The following is a description of a gene set: species: Homo sapiens Human Gene Set: GOBP_PHOSPHATIDYLINOSITOL_3_KINASE_PROTEIN_KINASE_B_SIGNAL_TRANSDUCTION An intracellular signaling cassette that starts with phosphatidylinositol 3-kinase (PI3K) activation, production of phosphatidylinositol 3-phosphate (PI3P), activation of PDK1, which recruits and ending with the activation of protein kinase B (PKB, also known as Akt). PI3K is activated by cell surface receptors. Note that PTEN is an inhibitor of the pathway., and this is the list of marker genes: FYN (NCBI Gene Id 2534), IGFBP5, WDR91, MYO16 (NCBI Gene Id 23026), PIP5KL1, THEM4 (NCBI Gene Id 117145), PROS1, INPP5F, MYORG, DCN, NTRK3, PRKD1, MYOC, NTF3, CHI3L1, RAC1, NYAP2, ADRA2C, STK11, SEMA3E, PLXNB1, C1QTNF1, SEMA5A, MUL1, CRYBA1, PDGFC, HAX1, DDR1, FCGR3A, NLRC3, RGL2, C1QTNF12, PIK3R3, INPP5K, PEAR1, CBL, COL6A1, RGCC, C1orf54, SELP, PECAM1, FERMT2, RCN3, ADAM8 (NCBI Gene Id 101), SPRY2, SRC, CD160, PINK1, HIP1, PDCD6, MIRLET7F1, SESN2, CCL3, INS, FAM110C, CRNN, RASGRP1, PIK3CG (NCBI Gene Id 5294), OSBPL8 (oxysterol binding protein like 8), TNF, COL6A3, TREM2, ARRB2, DDR2, PIK3CD, CAV3, PLEKHA1, ADAM17, MTDH, NOX4, TGFB2, SRPK2, CSF1R, JAK2, EGFR, CAVIN3, DRD2, PIK3IP1, MIR29B1, IGF1R, NTS, MIR138-1, PPP1R16B, HCST (hematopoietic cell signal transducer), DIPK2A, MIR126 (microRNA 126), DDIT3, GPX1, ADRA2A, ADRA2B, EPHA8, PREX2, RASD2, FAM3C, RELN, TNFSF11, CCL19, PIP5K1C, PPP2R1A, PHLPP1, F2R, MTOR, FKRP, AKT1, CX3CL1, CCR7, PKHD1, MIR34B, PPP2CA, GFRAL, MIR199A1, FLT3, HCLS1, GAB2, CX3CR1, EFNA5, MIR21, THBS1, MAZ, MIR146A, STK3 (serine/threonine kinase 3), TEK, PRR5, LEMD2, NTRK2, PIK3CA, SESN3, BTN2A2 (butyrophilin subfamily 2 member A2), PIK3R5, CSF3, INSR, RICTOR, C1QBP, ADTRP, EDN1, GAB1, PTK2, RTN4, PHB1, PIK3R1, MMP3, GPER1, KIT, TSPYL5, NRXN1, ATG14, PDPK1, NTRK1, MIR675, HGF, VAV1, ERBB3, SPECC1L, SERPINE2, AIM2, FGFR3, TSC2, STAMBP, PPARA, F2, CDC42, LEP, ERBB2, CPNE1, NOP53, DAG1, MIR29A, VAV2, MERTK, VEGFB (NCBI Gene Id 7423), AKR1C3, IL1B (interleukin 1 beta), CEACAM1, AXL, PIK3AP1, MIR34C, SERPINA12, COL6A2, PPARD, PIP5K1A, FSHR, TXN, NHERF1, ARFGEF1, PIK3C2B, MYDGF, THPO, PTPN11, MSTN, TGFBR1, PIK3C3, BECN1, LIN28A, FLCN, SESN1, EPHA7, TWIST1, PIK3R4, SMPD3 (NCBI Gene Id 79756), PDGFRB, TPBG, CAT, P2RY12, SFRP5, NGF (NCBI Gene Id 4803), FGFR1, INPP5E, BTBD10, PDGFA, ANGPT1, UBE3A, ERBB4, CEP55 (NCBI Gene Id 94765), OSM, BAG4, SIRT1, IL18, GATA3, VEGFA, IGF2, STOX1, PIP5K1B, GH1, FBXL2, IL26, WNT16, UNC5B, ERRFI1, RACK1, HPSE, HLA-G, RNF41, PTPN1, P2RX4, PRKCA, MFHAS1, ITGB1BP1, IFT80, MAGI2, IAPP, USP49, AMBRA1, LOX (NCBI Gene Id 4015), MIR20A, TYRO3, FPR2 (formyl peptide receptor 2), ZFP36L1, PARK7, ERFE, AKR1C2, MTM1, CD19, PIK3R2, DAB2IP, CD28, ILK, MIR34A (NCBI Gene Id 407040), CCL5, IGF1, EGF, PTPN6, IL1R1, EXTL3, ITGB1, CALCR, RYK, OTUD3, HBEGF, SH2B3, RRAS, XBP1, NKX3-1, RUBCN, PTPRJ, APP, MIR449A, SIRT7, NEDD4, PDGFB, BANK1, KDR (kinase insert domain receptor), VAV3, NF1, MIR206, GAS6, PDE3B, FLT1, PIK3C2G, PIK3CB, MIR29C, NDP, STAT3, WNT5A, DLG1, LRP2, LIME1, HYAL2, CCDC88A, FN1, IRS2, MST1R, PHLDA3, NYAP1, INPPL1, TCF7L2, FER, RAPGEF3, CIB1, F2RL1, KLF4 (NCBI Gene Id 9314), PIK3C2A, GCNT2, MIR145, IRS1, GDF15, PDGFD, PLK3, TGFB1, GRM2, CASS4, ENG, PRR5L, MKRN2, CD2AP, RAMP3, CCL21, SEMA4D, FGF2, MIR375, PDGFRA, CD40, DRD3 (NCBI Gene Id 2111), RET, TMEM100, PTK2B, PTEN, LTK, KBTBD2, FGR, PTPN13, AGT (NCBI Gene Id 183)